Given this list of marker genes SLC27A2, CYP7A1, BAAT, NR1H4, CYP7B1, AKR1C2, CYP27A1, HSD3B7, ACOT8, AKR1D1, NCOA2, RXRA, AMACR, ABCB11, SLC27A5, CYP8B1, HSD17B4, ACOX2, AKR1C3, AKR1C4, NCOA1 (NCBI Gene Id 8648), SCP2, AKR1C1, here is a description of the gene set: species: Homo sapiens In the liver, synthesis of bile acids and bile salts is initiated with the conversion of cholesterol to 7alpha-hydroxycholesterol and of 7alpha-hydroxycholesterol to 4-cholesten-7alpha-ol-3-one. The pathway then branches: hydroxylation of 4-cholesten-7alpha-ol-3-one to 4-cholesten-7alpha, 12alpha-diol-3-one leads ultimately to the formation of cholate, while its reduction to 5beta-cholestan-7alpha-ol-3-one leads to chenodeoxycholate formation. The amounts of substrate following each branch appear to be determined by abundance of the hydroxylase enzyme: in human liver, cholate synthesis predominates.<p>In both branches, reactions in the cytosol, the mitochondrial matrix, and the peroxisomal matrix result in modifications to the ring structure, shortening and oxidation of the side chain, conversion to a Coenzyme A derivative, and conjugation with the amino acids glycine or taurine. In the body, glycocholate, taurocholate, glycochenodeoxycholate, and taurochenodeoxycholate are released from hepatocytes into the bile and ultimately into the lumen of the small intestine, where they function as detergents to solubilize dietary fats. The liver synthetic pathway also yields small amounts of bile acids, cholate and deoxycholate, which may play a feedback role in regulating the bile acid synthetic pathway. These reactions are outlined in the figure below. part of: Synthesis of bile acids and bile salts Reactome Pathway: Synthesis of bile acids and bile salts via 7alpha-hydroxycholesterol